The following is a description of a gene set: Cancer and embryonic stem cells exhibit similar behavior, including immortal, undifferentiated, and invasive activities. Here, we show that in clinical samples bladder tumors with intense expression of stem cell marker Oct-3/4 (also known as POU5F1) are associated with further disease progression, greater metastasis, and shorter cancer-related survival compared with those with moderate and low expressions. Expression of Oct-3/4 is detected in human bladder transitional cell carcinoma samples and cell lines. Overexpression of Oct-3/4 enhances, whereas knockdown of Oct-3/4 expression by RNA interference reduces, migration and invasion of bladder cancer cells. Oct-3/4 can up-regulate fibroblast growth factor-4 and matrix metalloproteinase-2 (MMP-2), MMP-9, and MMP-13 production, which may contribute to tumor metastasis. Finally, we show that Ad5WS4, an E1B-55 kD-deleted adenovirus driven by the Oct-3/4 promoter, exerts potent antitumor activity against bladder cancer in a syngeneic murine tumor model. Therefore, our results implicate that Oct-3/4 may be useful as a novel tumor biological and prognostic marker and probably as a potential therapeutic target for bladder cancer. from publication Chang CC, Shieh GS, Wu P, Lin CC, Shiau AL, Wu CL (PMID 18676852) Genes down-regulated by POU5F1 in bladder cancer cell lines. Human Gene Set: CHANG_POU5F1_TARGETS_DN species: Homo sapiens, and this is the list of marker genes: TFPI2, PLPP5, SOCS3, GRSF1, POM121, TXNL1, TFEC, CST3